The following is a description of a gene set: Human Gene Set: GOBP_INDUCTION_OF_POSITIVE_CHEMOTAXIS species: Homo sapiens Any process that initiates the directed movement of a motile cell or organism towards a higher concentration in a concentration gradient of a specific chemical., and this is the list of marker genes: AGER, ARTN, CXCL8, IL16, VEGFB (vascular endothelial growth factor B), VEGFC, SCG2, PGF, FGF10, VEGFD, VEGFA, AZU1, NTF3, CREB3, CXCL12